Given this list of marker genes GADD45B, NFKBIZ, ID2, MAFF, PLK2, TRIB1, CITED2, IER2, NFKBIA, PPP1R15A, RASD1, DDIT3, BTG2, FOS, DNAJB1, RHOB, KLF6, MCL1 (NCBI Gene Id 4170), HSPH1, EGR1, CCN1 (NCBI Gene Id 3491), JUNB, HSPA1B, CCNL1, JUN, ID1, HES1, KLF4, ATF3, KLF10, DDIT4, HSPA1A, NR4A1, SERTAD1, HERPUD1, IER3, ID3, CDKN1A, DUSP1, SAT1, HSPA6, FOSB, EGR2, CXCL2, SOCS3, DNAJA1, ZFP36, PMAIP1, TOB1, IRF1, here is a description of the gene set: In this study, an extensive analysis was conducted to define meta-programs (MPs) capturing intra-tumor heterogeneity across a spectrum of tumor types. The approach utilized non-negative matrix factorization (NMF) to analyze each cell type separately within individual tumor samples. This involved the analysis of malignant cells, macrophages, fibroblasts, endothelial cells, epithelial cells, T-cells, and B-cells. NMF was executed with varying parameter values (K=4, 5, 6, 7, 8, 9), thereby generating 39 programs for each cell type per sample. Each NMF program was summarized by the top genes based on NMF coefficients.\nRobust MPs were then delineated for each cell type using a set of stringent criteria, including recurrence within the same tumor, similarity to programs in other tumors, and non-redundancy within a tumor. Subsequently, these robust NMF programs were clustered (per cell type) based on Jaccard similarity, leading to the identification of MPs associated with each cell type.\nTo enhance the quality of the MPs, a refinement steps were undertaken, involving the removal of MPs suspected of reflecting low-quality data (with an overrepresentation of ribosomal proteins or mitochondrial-encoded genes), single-study inclusion, or similarity to miss-annotated cell types. Genes upregulated in subsets of cells of a given type within various tumors from publication Gavish A, Tyler M, Greenwald AC, Hoefflin R, Simkin D, Tschernichovsky R, Galili Darnell N, Somech E, Barbolin C, Antman T, Kovarsky D, Barrett T, Gonzalez Castro LN, Halder D, Chanoch-Myers R, Laffy J, Mints M, Wider A, Tal R, Spitzer A, Hara T, Raitses-Gurevich M, Stossel C, Golan T, Tirosh A, Suvà ML, Puram SV, Tirosh I (PMID 37258682) species: Homo sapiens Human Gene Set: GAVISH_3CA_MALIGNANT_METAPROGRAM_5_STRESS